The following is a description of a gene set: Mouse Gene Set: GOBP_TIGHT_JUNCTION_ORGANIZATION studied in species Mus musculus A process that is carried out at the cellular level which results in the assembly, arrangement of constituent parts, or disassembly of a tight junction. A tight junction seals cells together in an epithelium in a way that prevents even small molecules from leaking from one side of the sheet to the other., and this is the list of marker genes: Cldn34c6, Cldn10, Pecam1, Nedd4l, Tjp1, Nphp1, Cldn13, Gpbar1, Cldn34b1, Samt1b, Cldn18, Afdn, Itgb1, Frmpd2, Pard3, Mpdz, Cldn34a, Ephb2, Cldn12, Rock1, Cldn23, Alox12b, Pkp2, Cldn1, Cldn34b3, Il1b, Patj, Acvrl1, Cldn34c4, Rock2, Cldn6, Dsg3, Tgfb3, Cldn34c5, Samt4, Prkaca, Cldn15, Abcc8, Cldn11, Slc39a9, Ikbkb, Pdcd6ip, Rps6-ps4, Actn4, Ocel1, Epha2, Cldn34c2, F11r, Snai1, Cldn17, Actg1, Rac1, Prkch, Fzd5, Rab13, Pof1b, Micall2, Tgfbr1, Srf, Cldn34c3, Cldn34d, Cldn4, Tbcd, Gja1, Grhl2, Cldn22, Svep1 (NCBI Gene Id 80647), Cldn2, Ect2, Marveld2, Samt2b, Cldn34c1, Tnf, Snai2, Cldn16, Esam, Wnt11, Marveld3, Ocln, Cgn, Ext1, Rps6, Myo1c, Arl2, Cldn24, Ildr1, Il17a, Lsr, Ramp2, Cldn7, Cldn8, Cldn34b4, Cldn34b2, Cdh5, Mylk3, Gdf2, Samt3, Pak2, Dlg1, Samt2, Cldn3, Cldn19, Cldn5 (claudin 5), Mpp7, Cldn9, Samt1d, Cdh1, Aloxe3, Cldn14, Plec, Nphp4